Given this list of marker genes Cops8, Cops4, Polr2g, Gtf2h2, Isy1, Cops2, Ccnh, Gtf2h5, Cops7a, Cdk7, Uba52, Cops5, Polr2l, Gps1, Cul4a, Xpa, Ercc2, Tcea1, Cops7b, Ercc3, Ercc6, Polr2h, Polr2a, Prpf19, Ubb, Polr2k, Cops3, Polr2f, Ubc, Usp7, Polr2e, Gtf2h1, Ddb1, Gtf2h4, Rbx1, Zfp830, Polr2b, Aqr, Cul4b (NCBI Gene Id 72584), Gtf2h3, Polr2i (NCBI Gene Id 69920), Polr2c, Mnat1 (NCBI Gene Id 320958), Xab2, Uba52rt, Cops6, Polr2d, Ercc8, Rps27a, Uvssa, here is a description of the gene set: Formation of TC-NER Pre-Incision Complex studied in species Mus musculus Mouse Gene Set: REACTOME_FORMATION_OF_TC_NER_PRE_INCISION_COMPLEX